Given this list of marker genes UCP3, POMC, HTR2A, TPH2, CFH, CST3, IRF6, NUP214, SERPINH1, A2ML1, NLRP1, ABCG8, TP53, BMP4, FKBP5, BCR, TAL1, HTRA1, ADRB3, FLT3, GNB1, STOX1 (NCBI Gene Id 219736), TAL2, SDC3, GHRL, NR0B2, AGRP, ENPP1, BAX, APOL1, PPARG, CARTPT, NBN, here is a description of the gene set: Polygenic inheritance Human Gene Set: HP_POLYGENIC_INHERITANCE A mode of inheritance that depends on a mixture of major and minor genetic determinants possibly together with environmental factors. Diseases inherited in this manner are termed complex diseases. studied in species Homo sapiens